The following is a description of a gene set: The formation of a tri-snRNP complex containing U4 and U6 (or U4atac and U6atac) snRNAs and U5 snRNAs and associated proteins. This includes reannealing of U4 and U6 (or U4atac and U6atac) snRNAs released from previous rounds of splicing to reform the U4/U6 snRNP (or U4atac/U6atac snRNP) as well as the subsequent association of the U5 snRNP with the U4/U6 snRNP (or U4atac/U6atac snRNP) to form a tri-snRNP that is ready to reassemble into another spliceosome complex. studied in species Mus musculus Mouse Gene Set: GOBP_SPLICEOSOMAL_TRI_SNRNP_COMPLEX_ASSEMBLY, and this is the list of marker genes: Usp4, Prpf19, Tssc4, Prpf8, Prpf3, Prpf31, Sart3, Aar2, Lsm2, Prpf4b, Prpf6